Given this list of marker genes Atf1, Creb1, Rps6ka5, Mapkapk2, Rps6ka3, Rps6ka1, Rps6ka2, here is a description of the gene set: studied in species Mus musculus CREB phosphorylation Mouse Gene Set: REACTOME_CREB_PHOSPHORYLATION